The following is a description of a gene set: Human Gene Set: HP_MULTINODULAR_GOITER Multinodular goiter Enlargement of the thyroid gland related to multiple nodules in the thyroid gland. studied in species Homo sapiens, and this is the list of marker genes: DICER1, KEAP1, AIP, GPR101, MAD1L1, SASH1, ALMS1